Given this list of marker genes Slc29a3, Slc22a2, Slc28a2, Slc29a4, Slc28a2b, Slc29a1, Slc28a1, Slc29a2, Slc25a26 (solute carrier family 25 (mitochondrial carrier, phosphate carrier), member 26), Slc28a3, Slc22a1, here is a description of the gene set: Enables the transfer of a nucleoside, a nucleobase linked to either beta-D-ribofuranose (ribonucleoside) or 2-deoxy-beta-D-ribofuranose, (a deoxyribonucleotide) from one side of a membrane to the other. studied in species Mus musculus Mouse Gene Set: GOMF_NUCLEOSIDE_TRANSMEMBRANE_TRANSPORTER_ACTIVITY